Given this list of marker genes BPIFB1, RPL39, DEFA5, H2BC7, CAMP, LTF, H2BC8, DEFA4, H2BC21, NOS2, APOA4, DEFA1, RNASE2 (ribonuclease A family member 2), DEFA1B, H2BC4, RNASE3, CLDN2, PLA2G1B, DEFA6, DEFB1, H2BC12L, H2BC6, DEFA3, H2BC12, H2BC11, H2BC10, FAU, here is a description of the gene set: species: Homo sapiens Any process of the innate immune response that takes place in the mucosal tissues. Human Gene Set: GOBP_INNATE_IMMUNE_RESPONSE_IN_MUCOSA